Given this list of marker genes Asxl2 (ASXL transcriptional regulator 2), Fadd, Csf1, Rb1, Il34, Casp8, Hcls1, Ror2, Lif, Trib1, Id2, Tgfb1, Hsf1 (heat shock factor 1), Prkca, Ripk1, here is a description of the gene set: Any process that activates or increases the frequency, rate or extent of macrophage differentiation. Mouse Gene Set: GOBP_POSITIVE_REGULATION_OF_MACROPHAGE_DIFFERENTIATION species: Mus musculus